The following is a description of a gene set: An increased or decreased activity of the mitochondrial respiratory chain. Human Gene Set: HP_ABNORMAL_ACTIVITY_OF_MITOCHONDRIAL_RESPIRATORY_CHAIN Abnormal activity of mitochondrial respiratory chain species: Homo sapiens, and this is the list of marker genes: NDUFS6, LRPPRC, FBXL4, NDUFB3, TRIT1, COX4I1, COA6, NDUFS1, NDUFA10, NDUFC2, MRPS25 (mitochondrial ribosomal protein S25), VARS2, MRM2, NDUFA6, TRMT10C, NDUFAF8, PTCD3, EARS2, ATP5F1E, NDUFB11, NDUFV2, NDUFA12, LYRM7, SLC25A26, NDUFAF3, ATPAF2, NDUFV1, MECR, TEFM, ATP5F1D, FDX2, TAMM41, NDUFS7, NDUFAF5, COX6A2, GFM1, NDUFAF4, NDUFB10, SLC25A4, ELAC2, COX20, DGUOK, C1QBP, UQCRB, CHCHD10, MT-ND1, MGME1, TSFM, AHDC1, ISCU, ACAD9, OPA1, KARS1, MTRFR, PET100, TTC19, COX16, MRPS16, AFG3L2, RARS2, TXN2, CYC1, GATC, POLG, AGK, MRPS23, GTPBP3, NFS1, NDUFS2, SLC39A8, TIMMDC1, GFM2, MRPS22, QRSL1, CRLS1, COA8, NUBPL (NCBI Gene Id 80224), ISCA2, NFU1, NDUFAF2, NDUFB9, UQCC3, COX5A, SCN4A, NDUFS3, TMEM126B, PUS1, SUCLG1, MTFMT, FLAD1, MRPL39, NDUFA8, NSUN3, MPV17, SLC25A10, MT-ND3, IBA57, NDUFS8, COQ4, TIMM50, NDUFA13, TIMM22, MIEF2, NARS2, SUCLA2, YARS2, NDUFA2, NDUFB7, MTO1, MRPL12, CDK5, PET117, GFER, TRMT5, BOLA3 (bolA family member 3), NDUFA4, ATP5F1A, RRM2B, SDHD, SDHB, HACD1, NDUFS4, BCS1L, FOXRED1, COA3, NAXE, NDUFAF6, TMEM70, MT-ND2, MT-TL1, SFXN4, CARS2, COA5, MRPS14, TRMU, UQCC2, MT-TE, AARS2, UQCRH, SCO2, NDUFA9, NDUFA11, NDUFAF1, AIFM1, UQCRQ, TK2, NDUFA1, SDHA, NDUFB8